Given this list of marker genes ZP1, ZP2, PANX1, PATL2, TUBB8, WEE2, here is a description of the gene set: Abnormal oocyte morphology studied in species Homo sapiens An abnormal structure of the female germ cell (egg cell). Human Gene Set: HP_ABNORMAL_OOCYTE_MORPHOLOGY